The following is a description of a gene set: species: Mus musculus Transcription factor Foxp3 (forkhead box P3), restricted in its expression to a specialized regulatory CD4+ T-cell subset (T(R)) with a dedicated suppressor function, controls T(R) lineage development. In humans and mice, Foxp3 deficiency results in a paucity of T(R) cells and a fatal breach in immunological tolerance, causing highly aggressive multi-organ autoimmune pathology. Here, through genome-wide analysis combining chromatin immunoprecipitation with mouse genome tiling array profiling, we identify Foxp3 binding regions for approximately genes and for an intergenically encoded microRNA. We find that a large number of Foxp3-bound genes are up- or downregulated in Foxp3+ T cells, suggesting that Foxp3 acts as both a transcriptional activator and repressor. Foxp3-mediated regulation unique to the thymus affects, among others, genes encoding nuclear factors that control gene expression and chromatin remodelling. In contrast, Foxp3 target genes shared by the thymic and peripheral T(R) cells encode primarily plasma membrane proteins, as well as cell signalling proteins. Together, our studies suggest that distinct transcriptional sub-programmes implemented by Foxp3 establish T(R) lineage during differentiation and its proliferative and functional competence in the periphery. Mouse Gene Set: ZHENG_FOXP3_TARGETS_IN_T_LYMPHOCYTE_UP Genes with promoters bound by FOXP3 and which are up-regulated only in mature (peripheral blood) regulatory CD4+ T lymphocytes. from publication Zheng Y, Josefowicz SZ, Kas A, Chu TT, Gavin MA, Rudensky AY (PMID 17237761), and this is the list of marker genes: Cc2d2a, Sgip1, Samsn1, Vrk2, Gata3 (NCBI Gene Id 14462), Zfp608, Cpm, Stard6, Gpld1, Flicr, Rras2, Ift57, Cenpk